Given this list of marker genes MELK, CRELD2, UBE2S, DTYMK, NPW, PTGES3, ARHGAP11A, SMS, KCTD4, H2AX (H2A.X variant histone), JPT1, CBX5, CENPM, MCM4, TMEM45A, UHRF1, MCM10, ECI1, HMGN3, KHDRBS1, KIAA0586, NXPH4, NCAPD3, PPP1CC, TP53I13, EXOSC3, KIF15, MRPL51, CANX, HNRNPA3 (heterogeneous nuclear ribonucleoprotein A3), PSME2, DNAJC9, COMMD4, LMNB1, NCAM1, TEX30, KIF20B, PIN1, CDK2, TUBB2B (tubulin beta 2B class IIb), RPA3, SET, CDK5RAP2, C12orf75, MYBL1, RNASEH2A, KIF14, CCNB1, GGH (NCBI Gene Id 8836), ZNF395, UBA2, VKORC1 (NCBI Gene Id 79001), MCM3, DDX11, KIF4A, SAP30, SRSF3, NCAPG2, CDCA2, MRPL17, NUSAP1, YWHAH, FABP5 (NCBI Gene Id 92424), NCAPD2, CDT1, GTSE1, PARPBP, ZGRF1, MXD3, ANP32E, PKM, PAFAH1B3, EFNA3, CMC2 (C-X9-C motif containing 2), ANKRD36, FLOT1, DIAPH3, TFDP1, DCK, FANCI, CCDC14, SLC25A5, HMGB1, PRC1, TRIR, ACYP1, ERH, CEP57L1, CDK1, LSM8, CDC25B, BANF1, FUS, DUT, HP1BP3, ZNF738, RACGAP1, PIMREG, RTN3, ARPP19, PPP1R1B, ITM2C, C21orf58, PSMG2, C1QL1, NEIL3, SUGP2, ZMYM1, TACC3 (transforming acidic coiled-coil containing protein 3), ECT2, G2E3 (G2/M-phase specific E3 ubiquitin protein ligase), CEP295, KIF2C, HNRNPH3, REEP4, SDC1, CAPG (capping actin protein, gelsolin like), MORF4L2, HSPA13, IFT25, RALBP1, PRELP, CEP192, TPR, CA9, CENPT, TUBGCP3, CENPO, UBE2T, CHEK1, TGIF1, ARHGAP33 (NCBI Gene Id 93092), TPGS2, MAD2L1, CDK4, SAMD1, PCLAF, H2BC11, SAC3D1, ATAD2, FBL, SSRP1, INSIG1, SYTL2, PA2G4 (NCBI Gene Id 5036), CCNB2, UBB, ACTL6A (actin like 6A), RRM2, MMS22L, PPP1R35, MZT1, DTL, CEP152, CRNDE, NT5DC2, POLD2, TMEM97, CEP70, CKAP2L, CCDC34, PRADC1, KNSTRN, SPC24, SLBP, NSD2, ORC6, TUBB, KIF23, HSPA8, PSMC3, PTTG1, CENPN, HCFC1R1, NRM, ATP2B1, NUCKS1, PSIP1, CENPE (NCBI Gene Id 1062), VBP1, HSP90B1, TPI1, SFPQ, ARL6IP1, ARHGEF39, NASP, CBX3, BCL7C, SRSF10, SNRPG (small nuclear ribonucleoprotein polypeptide G), PBK, KIF5B, PDIA6, MAMSTR, CENPF, MZT2B, NEK2, RBMX, HMGN2, GPX4, RNF26, CD320, EMC9, H2AZ1, TET1, COPRS, BRD8 (NCBI Gene Id 10902), RAD51AP1, SGO1, MAD2L2, CCNA2, POLE3, BUB3, BUB1B, CDCA5, CNTRL, ACTN4, NAV2, DEK, CENPQ, PITHD1, NGLY1 (NCBI Gene Id 95041), CKS1B, EMP3, RNASEH2C, HNRNPF, MTFP1, RFC5, LMF2, C5orf34 (chromosome 5 open reading frame 34), ANLN, PSRC1, KMT5A, TCEAL2, DHFR, TYMS, CTDSPL2, PPM1G, RIF1, PXMP2, SYPL1 (synaptophysin like 1), GCHFR, TMEM107, HLTF, PTBP1, EFEMP2, NUCB2, PRIM1, RFC2, TOP2A, MZT2A, ATAD5, CSE1L, VEGFB, RASSF1, RAD1, RNPS1, KNL1, CENPC, DBF4, MNS1 (NCBI Gene Id 55329), C19orf48P, CENPX, NDC80, GMNN (NCBI Gene Id 51053), HAT1, PAICS, AGPAT5, SNRPD3, PSMC3IP, POGLUT3, FIRRM (NCBI Gene Id 55732), ARMC1, TMEM18, HNRNPH1, HIF1A, RRM1, ERP29, MGME1, TMBIM6, KNTC1, USP1, TMEM106C, CYCS (NCBI Gene Id 54205), CAVIN3, HNRNPA0, KIFC1, H2AZ2, ZDHHC12, CDKN2D, SLF1, CENPW, H1-10, SKP2, AAMDC, THOC3, ARL6IP6, MCM5, WDR76, FOXM1, H1-4 (H1.4 linker histone, cluster member), TUBA1B, RSBN1, CENPJ, SHCBP1, PHF19, DDB2, DDX39A, CDC20, SMC3, BUB1, WDR54, RALY, MANF, TUBB6, ENO1, PPP1R3C, SMC4, SUPT16H, XRCC6, AURKB, TUBG1, MKI67, BIRC5, HYI, CNIH4, MIS18BP1, CDCA8, DYNC2I2, SLC2A4RG, RCC2, PPIH, BRCA2, TK1, EEF1AKMT2, TRIM59, SLC20A1, NAP1L1, PHPT1, SKA2, CDC25C, PHGDH, ZWINT, B3GAT3, MAZ, SIVA1, MACROH2A1, GGCT, PTX3, CIP2A, CCDC74A, PARD6G-AS1, HNRNPA2B1, UBE2I, WEE1, RARRES2, AKR7A2, FBXO5, CKS2, SGO2, GPT2, HSPD1, PCNA (proliferating cell nuclear antigen), SLC27A3, HPRT1, NDE1, CENPH, NDUFA4L2, UBE2C (ubiquitin conjugating enzyme E2 C), TTK, E2F1, FIBP, NUDCD2, IQGAP3, CENPL, POC1A, DEPDC1, MTHFS, PRKDC, GPN3, ESCO2, CKAP2, CALM2, SUN2, SRSF2, LMNB2, PRIM2, NCAPG, IKBIP, RMI1, KIF11, NDUFAF3, TECR, ANKRD36C, RETREG2, CCDC77, BTG3, WDHD1, RPL39L, CLEC11A, RANBP1, ILF2, RFC3, SYNE2, SPIN4, CD59, BRCA1, RNF5, RBBP4, EIF4A3, PGAM1, SDCBP, TUBA1C, PLK4, CENPU, BHLHE41, GPAA1, LSM5, HMMR, CDKN3, ASPM, EBP, KIF20A, DRAP1, RAD21, RFC4, HJURP, CBX1, CKLF, DYNLT1, CALM3 (calmodulin 3), PLP2, ARPC1A, SNRPD1, CEP44, TMPO, DNMT1, RMI2, MPHOSPH9, SNRPB, COX20, LMO7, EZH2, BARD1, FAM83D, H2AC14, CNPY3, TROAP, LIG1, SPAG5 (NCBI Gene Id 10615), DLGAP5, HELLS, SNAPC1, DCTN3, CCDC18, TOPBP1, PDIA3, SPC25, BLOC1S1, CKAP5, FBLN1, GAS2L3, SPAG4, PARP2, HACD3, TCF19, SLC43A3, MND1 (meiotic nuclear divisions 1), SLC25A11, CDCA4, CDCA3, NONO, BEND5, ITGB3BP, LSM3, CCDC167, RBBP7, EXOSC8, CCP110, LSM4, SKA3, RUVBL2, RHEB, SHMT2, RAD23A, E2F7, SMCHD1, CENPK, HMGB2, HIRIP3, CIT, SMC2, ALYREF, UQCC2, GINS2, ILF3, CA8, TCEAL7, SRSF7, POLR2H, TPX2, ISOC1, H1-3, SERBP1, CEP97, CDKN2C, MCM2, LCORL, CDCA7L, POLD3, ANAPC11, PLK1, SAE1, NUP35, ARL2, ZNF367, NUF2, RBM8A (RNA binding motif protein 8A), GUSB, MCM7, HDGF, PMM1, KIF22, here is a description of the gene set: from publication Su Z, Ho JWK, Yau RCH, Lam YL, Shek TWH, Yeung MCF, Chen H, Oreffo ROC, Cheah KSE, Cheung KSC (PMID 38267611) Human Gene Set: SU_HO_FOETAL_FEMUR_C3_PROLIFERATING_CHONDROCYTE The transformation of benign lesions to malignant tumours is a crucial aspect of understanding chondrosarcomas, which are malignant cartilage tumours that could develop from benign chondroid lesions. However, the process of malignant transformation for chondroid lesions remains poorly understood, and no reliable markers are available to aid clinical decision-making. To address this issue, we conducted a study analysing 11 primary cartilage tumours and controls using single-cell RNA sequencing. By creating a single-cell atlas, we were able to identify the role of endoplasmic reticulum (ER) stress in the malignant transformation of conventional central chondrosarcomas (CCCS). Our research revealed that lower levels of ER stress promote chondrosarcoma growth in a patient-derived xenograft mouse model, while intensive ER stress reduces primary chondrosarcoma cell viability. Furthermore, we discovered that the NF-?B pathway alleviates ER stress-induced apoptosis during chondrosarcoma progression. Our single-cell signatures and large public data support the use of key ER stress regulators, such as DNA Damage Inducible Transcript 3 (DDIT3; also known as CHOP), as malignant markers for overall patient survival. Ultimately, our study highlights the significant role that ER stress plays in the malignant transformation of cartilaginous tumours and provides a valuable resource for future diagnostic markers and therapeutic strategies. This cluster of proliferating chondrocytes expressed typical mitotic markers such as MKI67, TOP2A, and BIRC5. These cells represent an intermediate stage during the differentiation process of chondrocytes. studied in species Homo sapiens